The following is a description of a gene set: studied in species Mus musculus The directed movement of calcium ions into a sarcoplasmic reticulum. Mouse Gene Set: GOBP_CALCIUM_ION_IMPORT_INTO_SARCOPLASMIC_RETICULUM, and this is the list of marker genes: Mrln, Zmpste24, Pln, Atp2a1, Atp2a2, Hrc, Strit1